Given this list of marker genes Gm41381, 1700129L04Rik, Panx2, Gm44502, Mlc1, A930027H12Rik, Lrrk2, Cntn1, Gm18814 (NCBI Gene Id 100417770), Pim3, Gm15609, Dennd6b, Adamts20, Gm26760, Mapk8ip2, Rabl2, Smgc, Ppp6r2, Gm36330, Sco2, Mir6959, Tafa5, C230037L18Rik, Mir7118, B230214G05Rik, Alg10b, Gm18815, Ano6, Gm35772, Miox, Kif21a, 1810021B22Rik, Acr, Mapk11, Sbf1, Slc2a13, Mir6958, Gm8849, Klhdc7b, 9430014N10Rik, Syce3 (NCBI Gene Id 75459), Tmem117, Zdhhc25, Mir7648, Arsa, Gm36480, Gm18979, Gm8843, Gm30085, Gm20621, Dbx2, Gm26371, Gm30339, Gm7167, Gm6746, Yaf2, Cpt1b, Syt10, Tcea1-ps1, Rpl31-ps8, Prickle1, Gm8702, Cimap1b, Gm18476, C730034F03Rik, 4933438A12Rik, 4930445N06Rik (RIKEN cDNA 4930445N06 gene), A130051J06Rik, Zbed4, 4930588J15Rik, Gm4335, Alg12, Selenoo, Mapk12 (mitogen-activated protein kinase 12), Gm3861, Gm23129, Shank3, Pdzrn4, Gm24668, Adm2, Brd1, Mir6393, Pus7l, Lmf2, Trabd, Twf1, Zfp42-ps1, Gxylt1, Ttll8 (tubulin tyrosine ligase-like family, member 8), Hdac10, Redic1, Creld2, Ncaph2, Pphln1, Cpne8, Gm36618, Gm23737, Zcrb1, Abcd2, Plxnb2, Gm3888, Gm15383, Gm41386, Gm30564, Nell2, Gm18685, Gm15381, Spn-ps, Tubgcp6, Tymp, Chkb, Irak4, Gm15382, Mov10l1, here is a description of the gene set: Mouse Gene Set: chr15E3 studied in species Mus musculus